Given this list of marker genes VKORC1L1, SDHB, NDUFS7, AOC2, COQ10B, MT-ND4, NDUFS2, SQOR, TP53I3, VKORC1, AOC1, COQ10A, SDHD, ETFDH, CBR4, HSD17B8, AOC3, here is a description of the gene set: species: Homo sapiens Binding to a quinone, any member of a class of diketones derivable from aromatic compounds by conversion of two CH groups into CO groups with any necessary rearrangement of double bonds. Human Gene Set: GOMF_QUINONE_BINDING